The following is a description of a gene set: studied in species Homo sapiens Human Gene Set: GOBP_REGULATION_OF_EXTRINSIC_APOPTOTIC_SIGNALING_PATHWAY Any process that modulates the frequency, rate or extent of extrinsic apoptotic signaling pathway., and this is the list of marker genes: DEDD2, MIR221, PARK7, TCF7L2, CAV1, IFI6, PMAIP1, PRDX2, EYA4, GPER1, TNFSF10, TGFBR1, ITGAV, STRADB, HYAL2, TNF, TGFB2, KLF4, STK4, GCLM, SGK3, MAL, BID, PAK2, EYA1, EYA3, TNFSF12, BIRC6, PDIA3, FYN, NOL3, THBS1, DEPTOR, PPP2R1A, BCL10, CSF2, RPS6KB1, CTTN, TNFSF14, HMGB2, IGF1, ACSL5, SP100 (NCBI Gene Id 6672), APP, TMC8, SIAH2, CYLD, CD40LG, SNAI2, AR, SRPX, MAPK7, FGA, IL19, HGF, FASLG, TNFRSF12A, GRINA, PTPRC, FAIM, CX3CL1, SRC, ITGA6, IL1B (NCBI Gene Id 3553), CTNNA1, ARHGEF2, FGB (fibrinogen beta chain), AGT, TERT, COL2A1, LGALS3, TLR4, GATA1, LMNA, NF1, ATF3, STX4, TNFSF11, NOS3, SFRP1, ZMYND11, ICAM1, FADD, LTB, IL1A, GSTP1, FGFR1, SERPINE1, SKIL, CFLAR, SFRP2, BCL2, FEM1B, PAK5, AKT1, INHBA, MAP2K5, TLR6, MCL1 (NCBI Gene Id 4170), BMPR1B, RELA, LTA (NCBI Gene Id 4049), TNFSF15, FGF10, G0S2, PML, ITM2C, BCL2L14, HMOX1, FAF1, FAIM2, GPX1, NRP1, RAF1, STK3, WWOX, PF4, TNFAIP3, BCL2L1, MIR142, RNF34, DBH, BMP5, LTBR, ACVR1, UNC5B, PYCARD (NCBI Gene Id 29108), DDX3X, PHIP, YAP1, MIR222, RBCK1, HSPA1A, GSK3B, C8orf44-SGK3, SCRT2, AGTR2, TRAF1, PSME3, HSPA1B, PELI3, HTRA2, FGG, BRCA1, RIPK1, TMBIM1, MIR199A1, GDNF, MADD, PEA15, EYA2, IL7, TRAF2, ZSWIM2, SCG2, GCLC, ITPRIP, PPP1CA, HTT, NRG1, GFRAL, PPP2R1B, BMP4, SH3RF1, RB1CC1, RFFL, RET